Given this list of marker genes CA3, NRG1, NDRG1, ADI1, CDO1, here is a description of the gene set: Human Gene Set: GOMF_NICKEL_CATION_BINDING Binding to a nickel (Ni) cation. species: Homo sapiens